Given this list of marker genes Snx10, Stoml1, Abcd4, Mir467a-10, Mir146, Abcg4, Mras, Mir467a-3, Trim25, Mir324, Pml, Mir27b, Tfrc, Nrp2, Mir363, Mir142, Eed, Spp1, Mir298, Spock2, Mir544, Zfp42, Vegfc, Spry4, Hnrnpu, Chchd4, Mir96, Mir339, Mir367, Mir671, Mir679, Mir592, Ina, Mir193b, Mir293, Sstr1, Rarg, Mir135a-1, Mir196a-1, Mir182, Mir470, Nfyb, Sdad1, Mir224, Ext1, Mir137, Rnmt, Ptp4a3, Mir362, Nme7, Lrba, Mir301b, Rps16, Mir191, Mir380, Mir493, Mir216b, Mir103-1, Mir467a-9, Ubtf, Calm4, Mir370, Mir92-1, Mir744, Mir135a-2, Gldc, Polr1f, Mirlet7e, Pax6, Mir210, Mir467a-8, Mpc1, Mir219a-1, Mat2a, Mir574 (microRNA 574), Padi2, Mir294, Mir7b, Mkrn1 (makorin, ring finger protein, 1), Gfpt2, Mir181a-1, Rnf138, Mir881, Mir196a-2, Mir680-3, Fzd4, Mir409, Rfx2, Mir365-1, Mir149, Mir130b, Mir687, Trim2, Xbp1, Mir185, Mir152, Eps8, Mir670, Kat6b, Mir342, Mir494, Mir500, Enah, Mir219a-2, Mir297c, Mir539, Mir376a, Mir335, Mir29b-2, Dtx1, Mir34a, Fgf4, Efhc2, Mir24-2, Mir665, Mir467a-6, Mir302b, Pmm1, Mir431, Wdr35, Mir489, Mir16-1, Gnpnat1, Rnf125, Pfkp, Mir199a-2, Mir382, Prdm5, Ubxn2a, Mir92-2, Shmt1, Mir467a-4, Mir340, Pdcd10, Nefh (neurofilament, heavy polypeptide), Mir291b, Mir217, Mir133a-2, Nr5a2, Mir302d, Kdm5b, Mir34c, Mir345, Socs3, Mir29a, Gstt2, Mir300, Nol8, Mir125a, Mir181c, Mir449a, Kdm3a, Rif1, Arid5b, Mir672, Klf5, Smad7, Mir465b-2, Mir106a, B3gnt2, Sycp3, Mir295, Cth, Mir19b-1, Smarca5, Gtf2h1, Mirlet7i, Creb1, Mir19b-2, Bspry, Mir450-1, Mir223, Mir878, Srm, Mir7-1, Lrrc2, Mir331, Pla2g10, Mir540, Mir200a, Syngr1, Mir374b, Mir302c, Sox1, Mynn, Mir9-3, Pcolce2, Mir532, Sbno2, Jarid2, Mir7-2, Mir410, Mir29b-1, Mir206, Tle4, Mir465c-2, Elavl2, Mir20b, Mir199a-1, Ildr1, Mir680-2, Hells, Mir292, Ncl, Pou5f1, Otx2, Gclm, Pcolce, Mir381, Mybl2, Mir125b-1, Mir103-2, Srsf3, Mir323, Mir27a, Myb, Mir365-2, Mir181a-2, Mir344, Mir291a, Tex14, Mir16-2, Cacnb4, Xrcc5, Mir125b-2, Mir29c, Mrpl15, Mir301, Slc25a5, Eif4a2, Mir150, Mcf2, Mir9-2, Spry2, Mir21a, Hk2, Mir433, Mir743b, Mir127, Mir28a, Mir542, Laptm5, Adam23, Mir190a, Mir100, Mir706, Sirt1, Fosl2, Mir325 (microRNA 325), Mir467a-2, Mir467a-7, Mir455, Mir467b, Mir676, Mir9-1, Mir449c, Mir434, Foxd3 (forkhead box D3), Piga, Mir1a-1, Srsf7, Mir485, Mir133a-1, Mir465b-1, Mir467a-5, Klf4, Mir344-2, Mir680-1, Mir200b, Mir190b, Sox17, Ctbp2, Mir296, Bclaf1, Nup35, Lrat, Cacybp, Phc1, Bcat2, Mir503, Mir99a, Mir204, Mir216a, Mga, Mir652, Mir18, Icam1, Eef1e1, Parp16, Mir369, Mir302a, Mir322, Mir290a, Mir183, Mir741, Mir384, Mir145a, Mir467a-1, Mtf2, Mir34b, Mir450-2, Mir465c-1, Mir211, Mir200c, Mir351, Egln3, Tnfsf11, Mir205, Msc, Mir764, Mir18b, here is a description of the gene set: species: Mus musculus Mouse Gene Set: GOBP_RESPONSE_TO_LEUKEMIA_INHIBITORY_FACTOR Any process that results in a change in state or activity of a cell or an organism (in terms of movement, secretion, enzyme production, gene expression, etc.) as a result of a leukemia inhibitory factor stimulus.